The following is a description of a gene set: Any process carried out at the cellular level that reduces or removes the toxicity superoxide radicals or hydrogen peroxide. species: Homo sapiens Human Gene Set: GOBP_CELLULAR_OXIDANT_DETOXIFICATION, and this is the list of marker genes: APOE, PRDX4, GSTT1, SELENOF, IPCEF1, ALOX5AP, PARK7, PRXL2A, NOS3, MGST1, PRDX2, APOA4, TPO, LPO, GSTZ1, HBM (NCBI Gene Id 445449), GPX1, DUOX2 (NCBI Gene Id 82430), GPX4, EPX, GPX7, GPX6, HBG1, GSTK1, NFE2L2, GSR (glutathione-disulfide reductase), GSTO2, NXN, TXNDC17, TXN, HBG2, MT3, GSTM2, GSTO1, SELENOW, HBD, GSTP1, GCH1, NQO1, PRDX6, HBZ, CD36, UBIAD1 (NCBI Gene Id 7801), MB, SESN1, FABP1, SESN2, AMBP, SOD2, PRDX1, PTGS2, GPX3, GPX8, PRDX3, PTGES, PTGS1, PXDNL, TXNRD1, FBLN5, APOM, PXDN, TP53INP1, TXNRD2, SRXN1, CCS, TXNDC2, ALB, GSTA1, S100A9, PRDX5, GPX5, LTC4S, CYGB, DHFRP1, KDM3B, CLIC2, NNT, HP, SELENOS, HBE1, GPX2, MGST2, SOD3, HBA1, HBQ1, ATP7A, HBA2, SOD1, DUOX1, MGST3, CP, DHFR, HBB, MPO, SELENOT, BMP7, TXNRD3, CAT